The following is a description of a gene set: Human Gene Set: GSE14769_UNSTIM_VS_60MIN_LPS_BMDM_UP studied in species Homo sapiens from publication Litvak V, Ramsey SA, Rust AG, Zak DE, Kennedy KA, Lampano AE, Nykter M, Shmulevich I, Aderem A (PMID 19270711) Genes up-regulated in comparison of unstimulated macrophage cells versus macrophage cells stimulated with LPS (TLR4 agonist) for 60 min. The innate immune system is a two-edged sword; it is absolutely required for host defense against infection, but if left uncontrolled can trigger a plethora of inflammatory diseases. Here we used systems biology approaches to predict and validate a gene regulatory network involving a dynamic interplay between the transcription factors NF-κB, C/EBPδ, and ATF3 that controls inflammatory responses. We mathematically modeled transcriptional regulation of Il6 and Cebpd genes and experimentally validated the prediction that the combination of an initiator (NF-κB), an amplifier (C/EBPδ) and an attenuator (ATF3) forms a regulatory circuit that discriminates between transient and persistent Toll-like receptor 4-induced signals. Our results suggest a mechanism that enables the innate immune system to detect the duration of infection and to respond appropriately., and this is the list of marker genes: GPR4, TAGLN3, HSBP1, NCKAP1L, ARL14EP, TIMM13, COPS5, TMX2, LTO1, COX8A, MRPL27, PPIL2, TXNIP, ECI1, SBNO2, GRIK4, ZNF688, C17orf75, SNHG10, LIPT1, GINS3, SCARNA13, FBXO41, PPIB (peptidylprolyl isomerase B, NCBI Gene Id 5479), TRIM65, NDUFA11, BOD1, FNDC5, BID, POLR2D, IP6K3, DUSP11, C16orf54, ZNF764, ZC3H14, IER5L, STX8, TMED4 (transmembrane p24 trafficking protein 4), CNR2, LYL1, EMC3, SHFL, MCFD2, UBE2G2, MAD2L1BP, APOBEC1, POU4F1, PTRH2, DAAM2, NDUFA3, CDC37L1, MED8, ACOT13, NSRP1, CHCHD4, NHLRC3, MFAP3, SDHB, ZNHIT1, INIP, AGPAT2, ATP5ME, AP3M2, TMEM218, MESD, SDHAF2, PABPN1, COX19, CYTH4, CDK20, BRD10 (NCBI Gene Id 158358), ARRDC3, SKA2, AKTIP, CASP2, MED17, RIT1, DERL2, RNFT2, C19orf53, LSM3, SLC25A45, OTULINL, SLC30A1, TOR4A, SEC61G, RNF181, WNT5B, FAM32A, TSPAN14, SMUG1, DNLZ, PARVA, MRPL57, PRKAB1, FBXO5, RPS27 (NCBI Gene Id 6232), PYCARD, ARMC7 (armadillo repeat containing 7), MRPL49, SLC66A1, BORA, MFSD12, CRKL, CCDC88C, GPA33, ARL8B (NCBI Gene Id 55207), BMF, DCAF7, PAQR7, EPM2AIP1, RMND5B, CCDC115, FAM219B, NT5M, N4BP3, MMADHC, DENND2D, YPEL5, CLIP1, NLRP9, FGD3, HMOX2, HID1, DDX17, APLF, MFSD5, USP30, IMP3, DANCR, METAP1, ELOVL1, DYNC1LI2 (NCBI Gene Id 1783), ATP5MC2, MRPL28, TLR4, PSMB10 (proteasome 20S subunit beta 10), OSTM1, SYS1, PEBP1, ZNF623, AIFM2, CDC16, BET1L, LHFPL2, TMED6, ATP6AP1, KANSL2, NFRKB, TMEM140 (transmembrane protein 140), CNIH1, CD300LB, VPS26A, EIF1B, HHEX, PHF23, PGP, SNHG3, FASTKD5, FDX1, ANKRD16, NUBP1, FAM76B, SLC25A6, BNIP2 (BCL2 interacting protein 2), CYB5R2, ARL6IP4, TMEM184A, PLEKHB2, SS18L2, ZNF322, CACYBP, LRRC75A, MKRN1, ZFP90, SLC39A3, ARRDC2, BTBD1, FBXL12, TMEM63C, ISL1 (ISL LIM homeobox 1), CBR3, TRMT6, TTC14, AHSG, BLOC1S2, MYL11, ALKBH7, BCLAF1, DNAJC8, BLVRA, BABAM1, ZNF124, CLEC1B, ENSG00000267882, IL18BP, MRPL43, ZNF770, H2AJ, RPUSD4